Given this list of marker genes NRP2 (neuropilin 2), DLG1, DLG3, DLG4, NRCAM, ANK1, CNTN2, here is a description of the gene set: Human Gene Set: REACTOME_NRCAM_INTERACTIONS NrCAM interactions species: Homo sapiens